Given this list of marker genes TUBB2B, LAMB2, VAMP1, NKX6-2, CHP1, TUBB3, SYT2, VMA21, TUBA1A, COL25A1 (NCBI Gene Id 84570), PHOX2A, KIF21A, SCO2, COLQ, HSD17B4, here is a description of the gene set: studied in species Homo sapiens Limited mobility of the eye within its socket. Human Gene Set: HP_LIMITED_EXTRAOCULAR_MOVEMENTS Limited extraocular movements